The following is a description of a gene set: Genes with high-CpG-density promoters (HCP) that have no histone H3 methylation marks in brain. from publication Meissner A, Mikkelsen TS, Gu H, Wernig M, Hanna J, Sivachenko A, Zhang X, Bernstein BE, Nusbaum C, Jaffe DB, Gnirke A, Jaenisch R, Lander ES (PMID 18600261) DNA methylation is essential for normal development and has been implicated in many pathologies including cancer. Our knowledge about the genome-wide distribution of DNA methylation, how it changes during cellular differentiation and how it relates to histone methylation and other chromatin modifications in mammals remains limited. Here we report the generation and analysis of genome-scale DNA methylation profiles at nucleotide resolution in mammalian cells. Using high-throughput reduced representation bisulphite sequencing and single-molecule-based sequencing, we generated DNA methylation maps covering most CpG islands, and a representative sampling of conserved non-coding elements, transposons and other genomic features, for mouse embryonic stem cells, embryonic-stem-cell-derived and primary neural cells, and eight other primary tissues. Several key findings emerge from the data. First, DNA methylation patterns are better correlated with histone methylation patterns than with the underlying genome sequence context. Second, methylation of CpGs are dynamic epigenetic marks that undergo extensive changes during cellular differentiation, particularly in regulatory regions outside of core promoters. Third, analysis of embryonic-stem-cell-derived and primary cells reveals that 'weak' CpG islands associated with a specific set of developmentally regulated genes undergo aberrant hypermethylation during extended proliferation in vitro, in a pattern reminiscent of that reported in some primary tumours. More generally, the results establish reduced representation bisulphite sequencing as a powerful technology for epigenetic profiling of cell populations relevant to developmental biology, cancer and regenerative medicine. studied in species Mus musculus Mouse Gene Set: MEISSNER_BRAIN_HCP_WITH_H3_UNMETHYLATED, and this is the list of marker genes: Sycp2, Npb, Sycp1, Papolb, Sec1, Bhlha15, Speg, Nrk, Adad1, Hormad1 (HORMA domain containing 1), Slc25a31, Rnf17, Mycs, 4930524B15Rik, Pdha2, Omp, Mael, 1700067K01Rik, Tdrd1, Fstl3, Naa11, Ezhip, Mtarc1, Dpep3, Pheta2, D1Pas1, Actl7b, Ttc22, Tnfrsf25, Spo11, Nscme3l, Pramel1, Taf7l, Des, Sycp3, Msh4, Eppk1, Ddx4, Fkbp6, Kcng1, Hsf5, Camkk2